Given this list of marker genes Tmem117, Sirt1, Poglut2, Lrfn4, Traf3, Klhdc3, Cdkn1a, Gpatch2, Krt4, Dusp2, Tmtc3, Lemd2, Bltp3a, Kctd15, Plekhf2, Rnf138 (NCBI Gene Id 80618), Gxylt2, Rnf214, Cercam, Ltbr, Fkbp1b, Ankrd13c, Unk, Tet2, Tubb2a, Kdm6b, Zfx, Gm10778, Srgap1, Tspan17, Rps20, Lamtor1, Frem2, Col27a1 (collagen, type XXVII, alpha 1), Trim37, Mfsd4b1, Myorg, Oxr1, Ppm1e, Tbc1d7, Slc25a53, Rab5a, Tmem164, Cd151, Cmpk1, Zbtb10 (NCBI Gene Id 99802), Dtx4, Rgs4, Runx1t1, Ythdf1, Cntn2, Matcap1, Cfap90, Zfp36, Slc16a1, Klhl18, Rusc2, Nav2, Sipa1l2, Sgcg, Adamts18, N4bp1, Ubn1, Ino80d, Pramel42, Diaph2, Kbtbd8, Zbtb5, Als2, Cacna2d2, Raph1, Ppip5k2, Patz1, Tshz3, Snrk, Mia3, Ppp1r13b, Laptm5, Ldlrad3 (low density lipoprotein receptor class A domain containing 3), Tgfb2, Spin4, Rnpepl1, Cdk13, Orai2, Adamts2, Tmeff1, Paip2, Cpne8, Gid4, Hacd1, Sppl2b, Zfp26, Col11a1, Adamts20, Tmem254, Abhd12, Dusp4, Trpv4 (NCBI Gene Id 80591), Chsy1, Tspan4, Mtx3, Dnmt3b, Sh3bp5l, Prrt4, Ttc22, Mapk10, Zfp91, Vcl, Ampd3, Mlxip, Aoc3, Casp2, Crocc2, Slc25a36, Strn3, Yif1b, Pramel60, Atrn, Aurkb, Gm715, here is a description of the gene set: Genes predicted to be targets of miRBase v22 microRNA mmu_miR_3547_3p in miRDB v6.0 with MirTarget v4 prediction scores > 80 (high confidence targets). studied in species Mus musculus from publication Chen Y, Wang X (PMID 31504780) Mouse Gene Set: MIR_3547_3P